Given this list of marker genes MIR495, MASTL, MIR638, DTL, RAB11A, CTDSP1, CENPJ, DPF1, ARID2, RRM2B, MIR193A, OBSL1, TRIP13, CUL9, CTNNB1, MUC1 (NCBI Gene Id 4582), CPSF3, RPA2, KNL1, MIR892B, ASNS, FOXM1, EREG, TCF3, E2F1, MNAT1, NOP53, NFE2L1, LSM11, CDK2, PTEN, BCL6, CDC6, MIR16-1, PRAP1, CD28, NHERF1, CCNB1, PSMG2, RBM46, ZNF655, PLCB1, GBF1, KIF20B, DYNC1LI1, CDC23, HEXIM2, CDK9, CDC25B, CDKN1A, EME1, PRMT2, KLHL22, USP2, STK35, SMARCE1, FGF10 (NCBI Gene Id 2255), MBLAC1, MTBP, BRSK1, CDC73, CLSPN, CDK3, HASPIN, TRIM39, NEK9, AFAP1L2, MIR29C, UIMC1, MCIDAS, SIK1, ZNF830, RDX, ATR, INTS3, MAP3K20, MDC1, APPL1, KCNA5, FBXO43, ABRAXAS1, KMT2E (NCBI Gene Id 84147), MEIS2 (Meis homeobox 2), TP73, TFAP4, NDC80, RRM2, MRE11 (NCBI Gene Id 4361), STIL, MEPCE, ANAPC2, INS, PTPN11 (protein tyrosine phosphatase non-receptor type 11), BRD4, LRP5 (NCBI Gene Id 8058), EIF4E, DRD3, NSMCE2, ZNF207, ZWILCH, TTK, RAD17, BRINP3, DACT1, USP22, PPP1R9B, BCL2, CDKN2C, TNF, NUF2, CKS2, RIOK2, SIRT1, PDGFB, ZMPSTE24, TFDP1, RBBP8, CDC25C (cell division cycle 25C), E4F1, SMOC2, MIR372, ORC1, RAD9B, CCNE1, AIF1, MYO16, SDE2, RAD21, GFI1B, ANLN, AURKB, MIR221, EDN1, PABIR1, ANAPC10, EZH2 (enhancer of zeste 2 polycomb repressive complex 2 subunit), KLHL18, BRINP1 (BMP/retinoic acid inducible neural specific 1), DYNLT3, CUL4B, SMARCC1, ERCC3, CTDSPL, NME6 (NCBI Gene Id 10201), RPRM (NCBI Gene Id 89990, reprimo, TP53 dependent G2 arrest mediator homolog), TTC28, FZD3, BIRC5, ATM, EME2, TFDP3, UBE2C, FOXG1, SMARCA4, CHFR, DUSP1, MRNIP, CCNH (cyclin H), CDC14A, PLK3, CCDC57, TTL, MIR15A, FBXO7, CKS1B, PKIA, MIR222, FAM107A, PKN2, CDKN2A, IL10, CDKN1C, IQGAP1, MIR451A, PSME1, CCL2, YTHDC2, MAD2L1, PML, SYF2, CDC14C, MKI67, CRLF3, HECW2, ANGEL2, INCENP (NCBI Gene Id 56989), CCDC8 (coiled-coil domain containing 8), TM4SF5, ZFP36L2, AURKA, HNRNPU, CDK7, BARD1, POLDIP2, HUS1B, DLGAP5, PLK1, PSME2, PKMYT1, CDK5RAP3, TPRA1, EIF4G1, CDC27, PTPN3, MIR214, PRMT5, ANAPC15, XRCC3, BMP7, RB1, WNT10B, PTPN6, CYP1A1, ANKRD17, AVEN, BUB1, CDC42, NKX3-1, BTG3, SMARCC2, PBRM1, NABP2, CYLD, ANXA1, NEK11, RFPL1, STAT5B, RAD51B, SPHK1, MIR208A, CDC25A, PAFAH1B1, MAD2L2, MBTPS1, FOXC1, DAPK3, MIR19B1, ASCL1, FGFR1, IGF1, MUS81, IER3, GMNN, ATAD5, PPP1R10, MIR133A1, AMBRA1, FOXA1, NABP1, DDR2, CENPE, DONSON, CDCA8, RBL2, GEN1, STOX1, BRCC3, MSH2, SCRIB, SKA3, CDC20, MAD1L1, SASS6, GPR132, DDX3X (NCBI Gene Id 730543), SH2B1, MIR26A1, CCND1, HOXA13 (homeobox A13), SMARCA2, NEK2, LSM10, FOXO4, SMARCB1, SKA1, PRKDC, KIF14, ARID1A, FBXO5, KANK2, MIR520H, RGCC, PINX1, BTN2A2, SENP2, NUSAP1, IK, CUL7, UBE2E2, NEK7, OVOL1, IL1B, FHL1, MIR520A, DUSP3, CENPF, BABAM2, PKD1, MIR133B, ZNF268, TICRR, PTCH1, AATF, BCL7B, HSPA2, ZFP36L1, INO80, RPTOR, ID2, IGF2, STAT5A, DBF4B, PHF10, CDC16, EGF, MTA3, PTENP1-AS, JADE1, SPDL1, CCND3 (NCBI Gene Id 896), HUS1, BABAM1, MARK3, PIM2, DDB1, APPL2, MIR29B1, CDK6, TOPBP1, MIR21, BCL7A, TGFB1, GIGYF2 (NCBI Gene Id 59281), SPC24 (NCBI Gene Id 147841), ETAA1, HDAC3, PKD2, TAOK2, PLK5, ERCC2, ANAPC7, TRIAP1, INSR, SETMAR, ADAMTS1, APP (NCBI Gene Id 351), TMOD3, RRM1, CDC14B, PIM3, ACTL6B, ANAPC5, WAC, NAE1, BRD7, PDGFRB, SIN3A, HES1 (hes family bHLH transcription factor 1), CUL4A, MIR134, HSF1 (heat shock transcription factor 1), LGMN, CDK5RAP2, SDCBP, AKT1, ANAPC1, BTC, E2F7, CDK4, ZC3H12D, TTLL12, CDK1, SMPD3, CDK2AP2, BRCA2, KNTC1, DGKZ, CDC7, CHMP4C, ASAH2, HECA, CDKN2D, PRP4K, MDM2, BRINP2, NBN, ZW10, ANAPC11, ANAPC13, MIR362, PIM1, CHEK1, PIN1, LCMT1, RNF20, PHIP, CDKN1B, EDN3, CAV2, FGF8, MEIOC (meiosis specific with coiled-coil domain), DCUN1D3, PDIK1L, TPR, YWHAE, BRCA1 (BRCA1 DNA repair associated), CDC26, MIR30C2, FBXO31, DMRT1, ANAPC4, DLG1, FZR1, GPNMB, ATF2, GTPBP4, GAS1, NEUROG1, DPF3, TP53, AURKAIP1, MIR195, BUB3, RAD50 (NCBI Gene Id 10111), NEK6, PRKCA, ANAPC16, MIR137, EIF4EBP1, RNASEH2B, USP44, ADAM17, FBXW5, BMP4, FOXN3, INHBA, BUB1B, SPC25, TOM1L2, CCND2, TGFA, RAD51C, BLM, UBD, RNF40, DPF2, SMARCD2, VPS4B, TAL1, PLRG1, TREX1, CHEK2, EGFR, MIR15B, PPP2CA, TERT, CACNB4 (NCBI Gene Id 785), MIR515-1, NLE1, BCL7C, SMARCD3, SHB, TAOK1, TOM1L1, MAEA (macrophage erythroblast attacher, E3 ubiquitin ligase), RAD9A, BID, PDXP, MAD2L1BP, SMARCD1, TIPIN, SLFN11, ACVR1, CUL3, FANCD2, TMEM8B, MIR519D, MIIP, ACTL6A, CTC1, ABL1, STK33, RPS27L, PHOX2B, NUP62, ZWINT, RPA3, RBL1 (RB transcriptional corepressor like 1), BORA, TRIM35, RCC2, INTS13, ACTB, L3MBTL1, XPC, TMEM14B, EPGN, RPS6KB1 (ribosomal protein S6 kinase B1), PSME3, VPS4A, INIP, CDCA5, CCNE2, NPM2, MIR29A, MBTPS2, CDKN2B, SIRT2, RCC1, THAP1, KCNH5, ZFYVE19, CTDSP2, CDCA2, ESPL1, ARID1B, IL1A, TAOK3, TEX14, KLF4, RFWD3, CDK10, WEE1, ECD, APC, RINT1, PBX1, KLF11, here is a description of the gene set: Any process that modulates the rate or extent of progress through the mitotic cell cycle. Human Gene Set: GOBP_REGULATION_OF_MITOTIC_CELL_CYCLE species: Homo sapiens